The following is a description of a gene set: species: Homo sapiens Human Gene Set: HP_FACIAL_ERYTHEMA Redness of the skin of the face, caused by hyperemia of the capillaries in the lower layers of the skin. Facial erythema, and this is the list of marker genes: ADGRE2, MBTPS2, C1QB, GJA1, GNB2, KCNQ2, ANAPC1, RHOH, RECQL4, USP8, AIP, BLM